The following is a description of a gene set: Human Gene Set: GOBP_APOPTOTIC_PROCESS_INVOLVED_IN_MORPHOGENESIS studied in species Homo sapiens Any apoptotic process that contributes to the shaping of an anatomical structure., and this is the list of marker genes: CRYAB, TNFRSF1B, NOTCH1, JAG2, HNF1B, TGFB2, SCRIB, FOXC2, BCL2L11, PAX2, FZD5, VDR, CDKN2A, BAK1, NKX2-5, LRP5, FOXC1, HAND2, BMP4, PML, LEF1, BAX, BMP7, PAX8, PPP2R1B, CRYAA, TNFRSF1A, SPI1, FGF4, CCN1